The following is a description of a gene set: studied in species Homo sapiens Combining with an extracellular messenger (called a death ligand), and transmitting the signal from one side of the plasma membrane to the other to initiate apoptotic or necrotic cell death. Human Gene Set: GOMF_DEATH_RECEPTOR_ACTIVITY, and this is the list of marker genes: EDA2R, TNFRSF19, TNFRSF1B, HSPA1A, TNFRSF4, TNFRSF18, FAS, TNFRSF25, NGF, NGFR, TNFRSF10A, TNFRSF10B, TNFRSF11A, EDA, TNF, TNFRSF1A, TNFRSF14